The following is a description of a gene set: RNA localization is important for the establishment and maintenance of polarity in multiple cell types. Localized RNAs are usually transported along microtubules or actin filaments and become anchored at their destination to some underlying subcellular structure. Retention commonly involves actin or actin-associated proteins, although cytokeratin filaments and dynein anchor certain RNAs. RNA localization is important for diverse processes ranging from cell fate determination to synaptic plasticity; however, so far there have been few comprehensive studies of localized RNAs in mammalian cells. Here we have addressed this issue, focusing on migrating fibroblasts that polarize to form a leading edge and a tail in a process that involves asymmetric distribution of RNAs. We used a fractionation scheme combined with microarrays to identify, on a genome-wide scale, RNAs that localize in protruding pseudopodia of mouse fibroblasts in response to migratory stimuli. We find that a diverse group of RNAs accumulates in such pseudopodial protrusions. Through their 3' untranslated regions these transcripts are anchored in granules concentrated at the plus ends of detyrosinated microtubules. RNAs in the granules associate with the adenomatous polyposis coli (APC) tumour suppressor and the fragile X mental retardation protein (FMRP). APC is required for the accumulation of transcripts in protrusions. Our results suggest a new type of RNA anchoring mechanism as well as a new, unanticipated function for APC in localizing RNAs. from publication Mili S, Moissoglu K, Macara IG (PMID 18451862) Transcripts enriched in pseudopodia of NIH/3T3 cells (fibroblast) in response to haptotactic migratory stimulus by fibronectin, FN1. studied in species Mus musculus Human Gene Set: MILI_PSEUDOPODIA_HAPTOTAXIS_UP, and this is the list of marker genes: KIAA1143, ACSL4, MYEF2, PTPN2, ACTR2, ZNF277, RPL17, USP46, RIOK3, ACTR6, EIF3E, MYO1H, C9orf85, NCOR1, LARP7, BUB1 (NCBI Gene Id 699), CHEK1, CRIPT, IFT74, PPFIA1, MAP2K7, ZNF326, ZEB1, SH3BGRL, SMIM13, MBNL2, PHLDB2, MATR3, TRIM44, DLG3, CPSF6, NAA30, MBIP, DPP8, UBE2V2, EIF3J, MSANTD4, NUDCD2, PTP4A2, ANAPC4, SERF1A, DCAF5, CSTF2, KRR1, IDI1, ZRANB2, TP53INP2, TOMM70 (NCBI Gene Id 9868), RALA, PSMC3IP, HNRNPA3, HES5, NR3C1, SMAP1, POLR1F, NUP54, SUMO1, RGS20, CELF2, TLK2, TTC33, ROCK1, TMEM263, OGFRL1, SLC4A1AP, CUL3, SAMD9L, PAIP1, UBE2D3, RYBP, STAG2, BCLAF1, ITGB3BP (integrin subunit beta 3 binding protein), EXOSC9, RAP1A, MTMR6, CAPZA1, KIF2A, NET1, PNO1, SS18L2, PPP1R7, RAB11A, IGF2BP2, PPHLN1, CYB5R4, ZDHHC2, SRP54, TSTD3, NFIA, STARD10, CHPT1, TMEM167A, NCOA2 (nuclear receptor coactivator 2), ERBIN, XAF1, SUCLA2, CAMK2D, USP24, RBBP8, TUBGCP4, FAM13B, GMPS, SSB, PPP3CA, ARMCX3, TXNDC9, UBE2D2, DDR2, SLTM, INTS8, USP16, CLOCK, PPP4R2, KPNA3, NAMPT, FYTTD1, CETN3, TCEA1, SERPINB9, SNX6, MRPS18C, COPS2, FXR1 (FMR1 autosomal homolog 1), BEND6, DYNLL2, AGGF1, CENPP, RPE, CCDC90B, TIAL1 (TIA1 cytotoxic granule associated RNA binding protein like 1), AGTPBP1, TBC1D8B, HERC4, PRPF40A (NCBI Gene Id 55660), AP4S1, TRAPPC8, YES1, MYO5A, ARMC1, KIF5B, PCNP, HTATSF1, IVNS1ABP, ARHGAP5 (NCBI Gene Id 394), VPS13A, ATP6V1D, VPS4B, PPP2R3A, AGFG1, CIP2A, DNAJB4, TIMM8A, TAF13, C5orf24, ORC2, STARD4, WWP1, HNRNPK, RPF2, STEEP1, FAM229B, VPS54, CISD2, QKI, NIPSNAP2, MTPAP, RPS20, GSPT1, IRGM, CENPQ, TRIP4 (thyroid hormone receptor interactor 4), SMIM15, ZBTB38, TRA2B, ZRSR2, PSMC6, LIMS1, C1D, LSM14A, CNOT7, MTAP, NAP1L1, MRPS14, MRPL47, HNRNPR, DCUN1D1, SLIRP, SRSF1, OLA1, BBIP1, CDKAL1, PCYT1B, LZTFL1, ORC3, CENPK, HDGFL3, GOLPH3, RAB5A, NAA50, CRBN, C1orf216, HIBCH, SYCP3, CYB5R3, SOS1, THOC7, CGAS, SMC5, CSNK1G3, CISD1, HMGN3, MAK16, PIK3C2A, CNOT2, UBR3, RWDD1, DYNLT3, DNAJC15, FGFR1OP2, WDR75, GPATCH4, RPL31, LST1, PDCD5, ANKRD11, MAPKBP1, RBIS, GPRASP3, ASNSD1, UBLCP1, XPO1, RABEP1, CTTNBP2NL, PAFAH1B1, SBF2, GNL2, SRSF11, MRPL13, PIP4K2A, THOC1, DNM1L (NCBI Gene Id 692222), HNRNPH2, DIXDC1, CCNG1, RTRAF, RPS6KA3, RBM34, CCDC141, UCHL5 (NCBI Gene Id 82736), NAA15, POLA1, YTHDC1, ABI2, ZFR, VBP1, UTP14A (UTP14A small subunit processome component), SELENOT, TIGD2, TANK, PDCD10, SF3B1, RAP2C, ARL6, PPP1R12A, RBM25, ACBD5, EIF4G2, IRAK1BP1 (NCBI Gene Id 80793), ZNF121, FRG1, RO60, CFAP97, EIF5B, NIFK, PPP1CB, SLU7, AK6, TBC1D12, KANK2, INTS13, RBM7, GAB2, CACYBP, SPRED1, DEK, SCP2, MFAP1, BZW1, VCPIP1, MPP7, WDR26, ZNF254, CENPB, DYNC1LI2, CHMP2B, GTF3C6, ST13, CARNMT1, WWTR1, PYHIN1, GDI2, METAP2, UBA3, YTHDF3, FKBP3, CHMP1B2P, EIF1AY, PRIM1 (DNA primase subunit 1, NCBI Gene Id 5557), ZNF131, RSPRY1, BTBD1, SARNP, SMC3, EMC2, CFDP1, ERI1, GTPBP4, DTNA, STAG1, FNDC3A, ATRX, TOPORS, DDX10, STYX, KIF1C, PWWP3B, CEBPZOS, ZNRF2, OPA1, RAB13, RNF6, SAMTOR, FAR1, SLC25A46, YWHAB, OXR1, TTC1, HMGCS1, TPD52, UFSP2, PPP4R3B, STRN, BORCS7, TNKS2, AASDHPPT, KCTD10, YAF2, FBXW2, RNF138 (NCBI Gene Id 51444), ZBTB12, MTHFD2L, ESCO1, SCRN3, SMCHD1, DYNLT2B, BTF3L4, NUSAP1, AP3M1, GKAP1, MRPS22, VAMP4, CCDC34, ATF2, SETD7, CD2AP, GPBP1, CAPZA2, COMMD8, GULP1, MFF, NPM1, MLLT3, PBRM1, DMXL1, INPP1, TCF12, ZNF24, YAE1, SACM1L, IQSEC2, SAMD4A, R3HDM1, HNRNPH3, PPWD1, PTPN4, PDK1, EIF2A, COP1, IWS1, RPL21, CCNH, LTN1, STRAP, MIB1, ERGIC2, MTPN, HIF1A, CAB39L, CYP2C18, PFN2, MID2, CFL2, MAPK8, RNF115, GMFB, FNBP1L, BCLAF3, SNX16, PDSS1, CDV3, SH3GLB1, MEF2A, ARPP19, NEMF, STRBP, MAP1B, CAVIN2, PTAR1, DCAF6, RASA1, YME1L1, COA5 (NCBI Gene Id 493753), CDC5L, IL2, ATE1, DOCK11, BMI1, MYCBP, IFTAP, TUT7, RPAP2, ZMYND11 (zinc finger MYND-type containing 11), SSBP1, ARL5A, SEPTIN6, PTP4A1, TENT2, VPS41, TAX1BP1, APC, DCLK1, CUL4B, PUM3, TOGARAM1, SMCO4, ZMAT2, TXNL1, SNHG6, RPS6KA6, TRAPPC2, ATR, MBNL1, NXT2, SYNJ2BP, LGALSL, RANBP6, CAMSAP2, SANBR, MRRF, SHOX2, C3orf38, SNAP23, CCNC, CUL2, WDR43, CEP83, HDAC2, CCNE2, PALLD, COX7B2, MKRN1, CRYZL1, FASTKD2, RAB8B, NUDT2, CENPU, IFIT2, EFR3A, RFLNB, NIPBL, PARP4, PJA2, WBP4, KRAS, ABCB7, TBC1D15, AHSA2P, TSR1, EIF2S2, NAE1, MRPL57, DKC1, ESF1, RBM41, UGP2, CTBP2, TRMT11, VTI1B, SEPTIN7, GNPNAT1, MOB4, SDHAF3, PSIP1, MRE11, SKP1, THUMPD3, SRSF3, SREK1IP1, FAM133B, DNAJA1, RP2, PSMD6, VPS35, FBXO32, ANKRD13C, SNX5, CCND2, YTHDF2, PKP4, PLEKHA8